Given this list of marker genes C6orf120, CTDSPL, GPC6, RORA, ZNF157, DHX35, TPM4, PLAGL2 (PLAG1 like zinc finger 2), ITGA5, FAM83H (NCBI Gene Id 286077), PLG, ARHGAP1, PDE7B, DRD2, SMPX, SOX6, UBP1, TBPL1, FBLN5, AHCY, CCNB1, CHP1, GPR107, PLPP6, SEPTIN8, FAM171A1, PDZD2, UBE2K, ANKRD42, SAYSD1, NTRK3, NABP1, PARP12, ZNF668, HSPA8, JOSD1, KAT6B, here is a description of the gene set: Human Gene Set: MIR3085_5P species: Homo sapiens from publication Chen Y, Wang X (PMID 31504780) Genes predicted to be targets of miRBase v22 microRNA hsa-miR-3085-5p in miRDB v6.0 with MirTarget v4 prediction scores > 80 (high confidence targets).